Given this list of marker genes A2m (NCBI Gene Id 232345), C4bp, Cd55, Zp3r, Cd59b, Masp1, Cr1l, Cr2, Cd46, Cd59a, Cd55b (NCBI Gene Id 98313), Susd4, Vsig4, Serping1, here is a description of the gene set: Mouse Gene Set: GOBP_NEGATIVE_REGULATION_OF_COMPLEMENT_ACTIVATION Any process that stops, prevents, or reduces the frequency, rate or extent of complement activation. species: Mus musculus